Given this list of marker genes Fabp12, Fabp6, Fabp2, Fabp5, Fabp7, Pnpla5, here is a description of the gene set: species: Mus musculus electronically inferred by orthology from the curated human pathway Reactome Pathway: Triglyceride catabolism This event has been computationally inferred from an event that has been demonstrated in another species.<p>The inference is based on the homology mapping from PANTHER. Briefly, reactions for which all involved PhysicalEntities (in input, output and catalyst) have a mapped orthologue/paralogue (for complexes at least 75% of components must have a mapping) are inferred to the other species. part of: Triglyceride metabolism